Given this list of marker genes BORCS7, DSEL, PPP1R1B, CD320, NNAT, KDM4C (lysine demethylase 4C), TRMT44, CCDC172, NDUFS8, ZNF703, PDX1, ASCC1, SOCS3, ZIC5, KCNK5, CDH2, MIR22HG, PSMD8, ZNF560, PPP1R15A, OPA3, APOO, CD69, SEC13, RASD1, MRPS18A, EGR1, FBP1, JSRP1, NT5C3A, EPX, FANCD2OS, GALNT9, ELOF1, ALKBH3, RAMP2, SMIM23, NKAPL, LTB, UCK1, PDE4B (NCBI Gene Id 5142), FHIT (fragile histidine triad diadenosine triphosphatase, NCBI Gene Id 2385), SERPINB12, CDK5, POP7, BAIAP2L1, EXOSC4, CYTH3, TMEM255A, GLB1L3, BTG2, UQCRC1, PCSK9, FBXO8, IER3, INTS12, ANKS3, TOMM20L, MRPL10, HAVCR1, INSM1, DNAAF8, EAPP (E2F associated phosphoprotein), LRRIQ3, DZANK1, ZFP36, EXOC7, RRAGA, SOST, SLX9 (SLX9 ribosome biogenesis factor), MYOT, HTRA1, DKKL1, C19orf25, GRB2, PDGFRL, RPS6KB2, ZNRD2, KPTN, MALT1, DNAJC24, ELAVL3, NRG3, RIC8B, PABPN1L, NXF3 (NCBI Gene Id 56000), WTAP, IER2, CZIB, UBE2N, GPN2 (NCBI Gene Id 54707), FOS, GEMIN7, SMIM20, CAPN9, CERT1, TREM2, ADAM22, PRKAG1 (NCBI Gene Id 5571), CCDC198, MBIP, TMEM222, FEZF1, SRRD, FZD2, NLRP3, PEBP4, RAI1, CFD, GJA5, TMEM128, ZFP42, KLHDC8A, SNRNP27, REX1BD, TENT5B, LRFN3 (leucine rich repeat and fibronectin type III domain containing 3), BRINP1, KDM6A, CARNS1, TAFA1, WDR18, SSR4, DNAJC5B, KLHL36, ILK, LMO1, SLC30A10, TNFSF9, RPL19, SOWAHC, CHST4, HMX2, DNAAF11, CNTN6, TBC1D21, COQ10B, HMG20B, NIPSNAP3A, DUSP1, GNA11, ROS1, COQ6, CIDEC (cell death inducing DFFA like effector c), GALK2, MRPL37, TCHHL1, ZNF652, CXCL3, ASPSCR1, RPP21, MRPL30, DDI1, AMPH, TLCD4, NLRP12, ANKRD39, DUSP2, NFKBID, CCDC183 (coiled-coil domain containing 183), ECH1, SMARCD3, SLC25A18, GGT7, IL10 (interleukin 10), GRIK2, GRID2, AUTS2, GLIS3 (NCBI Gene Id 648268), AHR, GMPPA, OLIG2, TEX13B, ODF1, OSM, KRT24, CTXN3, ARMCX5, ACAA2, MIF, FOSB, DPF1, SNRPA, PKHD1, PAFAH1B3, FBXO25, CEND1, IFT140, RSPH1, SEC22A, RASAL2, CXCL2, SIGIRR, FILIP1L, AMMECR1, HSPB8 (NCBI Gene Id 8097), FAM151B, SUN5, here is a description of the gene set: studied in species Homo sapiens Human Gene Set: GSE41176_WT_VS_TAK1_KO_ANTI_IGM_STIM_BCELL_3H_UP from publication Shinohara H, Behar M, Inoue K, Hiroshima M, Yasuda T, Nagashima T, Kimura S, Sanjo H, Maeda S, Yumoto N, Ki S, Akira S, Sako Y, Hoffmann A, Kurosaki T, Okada-Hatakeyama M (PMID 24833394) The activation signaling of transcription factor nuclear factor-kB (NF-kB) plays central role for immune system. One of key kinase mediating this pathway is TAK1 in adaptive and innate immunity. However, role of TAK1 in B cell receptor signaling is still unclear. To know effects of TAK1-deletion on the gene expression induced by anti-IgM, we performed the time course analysis in comparison of wild type with TAK1-deleted splenic B cells. Genes up-regulated in B lymphocytes treated by anti IgM for 3h: wildtype versus MAP3K7 knockout.